Given this list of marker genes HAUS3, TSPYL1, CHD1, RAB11FIP2, IFITM1, RGCC, ZNF331, TNFAIP3, TTC17, RPL38, ELF2, CIRBP, KAT6B, RORA, TIMP1, NEFL, PBXIP1, ATP2B1, ARHGEF18, ARL4A, EPHA4, NR4A2 (nuclear receptor subfamily 4 group A member 2), DYRK2, ATG14, JADE1, STOM (NCBI Gene Id 2040), RRN3P1, DAZAP2, KLF2, KLRG1, PELI1, LMX1B, TXNIP, PER1, CFH, FAM13A, HECA, FCGRT, CCNL1, ATXN7, TMEM127, PPP4R3A, COQ10B, LPIN1, MARCHF8 (NCBI Gene Id 220972), SARAF, TMEM185B, IRS2, KLF6, KLF3, MAPK1IP1L, SEMA4C, NCK2, RNF44 (NCBI Gene Id 260352), LEPROTL1, UVRAG, NDEL1, TMEM41B, MXI1, SPINK2, RABL3, PIAS2, CD300A, KLRB1 (NCBI Gene Id 3820), MX2, NKTR, PLK3, APBA2, PDCD4-AS1, RNF11, IFIT1, RLF, SIGIRR, MYLIP, SORL1, ZNF136, AMT, VCPKMT, KLHL20, RPS27, TSPYL2, ITPR3, TSC22D1, IL11RA, FOSB, HLA-G, SCML1, DUSP2, TMEM123, SMURF1, LINC00623 (NCBI Gene Id 728875), JADE2, DUSP1, NLRP3, NUP160, TSC22D3, DNAJB1, DNAJB9, UBL3 (NCBI Gene Id 5412), SGK1, CAPRIN2, TENT5A, PTGER4, BTG2, TSPYL4, PRKCB, TCTA, MGAT4A, SLC2A3, PATJ, PNISR, SERINC5, PHC1, HBB, MBIP, MGP, RAP1GAP2, PLCL2, JUNB, DYRK1A, KLF7, ENTPD4, GZMK, CRTC3, HLA-F, IL10RA, RASSF8 (Ras association domain family member 8), SETD2, TENT5C, ZFP36L2, TSPOAP1, CREBBP, DIDO1, CITED2 (NCBI Gene Id 154106), ZNF639, ANXA1, CD69, LYPD3 (LY6/PLAUR domain containing 3), PFN2, CLK1, TMEM63A, PXN, PPP1CB, MOAP1, CCDC59, MBNL2, YPEL5, TIPARP, KLF11, RHBDL1, RPL35A, FRAT1, KANSL2, RIPOR2, YTHDF3, ARL4C, CKAP4, CLK4 (NCBI Gene Id 57396, CDC like kinase 4), NBPF10, NAIP, FNDC3A, FBXO21, PCMTD2, DSTYK, KIAA0513, PIK3R1 (NCBI Gene Id 5295), CRY2, PTP4A1, CDR2, CNOT2, GPRASP1, NR3C2, IL7R, TOB1, CXCR4, RALGPS1, GOLGA4, USP34, JAM3, SH2B3, RNASET2, PIK3IP1, GPR183, IFITM3, ITGB2, RPL10L (NCBI Gene Id 140801), TNIK, IL6R, RALGAPA1, TMX4, RASGRP2, ADD3 (adducin 3), LONP2, USP3, SIK1, PIK3C2B, FOS (NCBI Gene Id 2353), MED6 (NCBI Gene Id 10001), here is a description of the gene set: With increasing age, the ability of the immune system to protect against recurring infections or to control chronic infections erodes. The objective of the current study was to identify gene expression signatures in elderly CD4 T cell responses from publication Yu M, Li G, Lee WW, Yuan M, Cui D, Weyand CM, Goronzy JJ (PMID 22434910) Genes up-regulated in comparison of untreated CD4 memory T cells from young donors versus those treated with TSST at 72 h. species: Homo sapiens Human Gene Set: GSE36476_CTRL_VS_TSST_ACT_72H_MEMORY_CD4_TCELL_YOUNG_UP